The following is a description of a gene set: Reactome Pathway: cGMP effects part of: Nitric oxide stimulates guanylate cyclase species: Mus musculus electronically inferred by orthology from the curated human pathway This event has been computationally inferred from an event that has been demonstrated in another species.<p>The inference is based on the homology mapping from PANTHER. Briefly, reactions for which all involved PhysicalEntities (in input, output and catalyst) have a mapped orthologue/paralogue (for complexes at least 75% of components must have a mapping) are inferred to the other species., and this is the list of marker genes: Pde2a, Pde5a, Pde10a, Pde1b, Pde9a (NCBI Gene Id 18585)